Given this list of marker genes Klk1b1, Ednra, Smad4, Ryr2, Naglu (alpha-N-acetylglucosaminidase (Sanfilippo disease IIIB)), here is a description of the gene set: The process in which the anatomical structures of left cardiac ventricle muscle are generated and organized. Mouse Gene Set: GOBP_LEFT_VENTRICULAR_CARDIAC_MUSCLE_TISSUE_MORPHOGENESIS studied in species Mus musculus